The following is a description of a gene set: Abnormal cervical spine morphology Human Gene Set: HP_ABNORMAL_CERVICAL_SPINE_MORPHOLOGY Any morphological abnormality of the cervical vertebral column. species: Homo sapiens, and this is the list of marker genes: FGFR3 (fibroblast growth factor receptor 3), DSE, SLC26A2, EBP, POGZ, DHX37, HTRA1, CHRNA1, CHRND, POLR3A, HSPG2, FUCA1, FLNB, SLC35B2, SOX9, GLE1, CHRNG, CHST14, RIPPLY2, GZF1, TRPV4, ARSL